The following is a description of a gene set: Human Gene Set: GOMF_HISTONE_OCTAMER_SLIDER_ACTIVITY studied in species Homo sapiens A chromatin remodeler activity that slides core histone octamers along chromosomal DNA., and this is the list of marker genes: RSF1, SMARCA1, SMARCA5, SMARCA4, SMARCA2, SMARCAD1